The following is a description of a gene set: Any process that modulates the rate, frequency, or extent of the series of molecular signals generated as a consequence of a transmembrane receptor serine/threonine kinase binding to its physiological ligand. Mouse Gene Set: GOBP_REGULATION_OF_TRANSMEMBRANE_RECEPTOR_PROTEIN_SERINE_THREONINE_KINASE_SIGNALING_PATHWAY studied in species Mus musculus, and this is the list of marker genes: Fkbp1a, Fzd1, Lrrc32, Fstl1, Kdr, Spart, Nrep, Amh, Lrg1, Ogt, Crb2, Ark2c, Fkbp8, Dnm2, Pin1, Tbx20, Smurf2, Dlx1, Cidea, Fstl3, Tnfaip6, Ing1, Fbn1, Nepn, Onecut2, Eng, Gata4, Ints9, Acvr2a, Gdf6, Nbl1, Sap30, Usp15, Sin3a, Men1, Rnf111, Ube2o, Ccn1, Tcf7l2, Fbn2, Sfrp1, Sfrp2, Trp53, Sfrp4 (secreted frizzled-related protein 4), Ovol2, Tgfb1i1, Adissp, Snx1, Zbtb7a, Spred2, Tmem53, Thbs1, Pals1, Pin1rt1, Spred3, Snx25, Chrdl1, Itga8, Gata6 (NCBI Gene Id 14465), Sostdc1, Dkk1, Snx6, Nanog, Zc3h3, Rgma, Myocd, Gdf15, Rbbp4, Ngly1, Dand5, Hdac2, Fst, Igsf1, Tgfb2, Cdkn1c, Chrdl2, Sulf1, Spred1, Hes1, Flcn, Emilin1, Nog, Adamtsl2, Slc2a10, Smad7, Numa1, Rbbp7, Sost, Brms1, Ski, Itga3 (integrin alpha 3), Lrp1, Hfe, Parp1, Suds3, Wnt5a, Neo1, Ppara, Arid4b, Vwc2l, Rasl11b, Cdh5, Aspn, Tgfbr2, Fstl4, Atoh8, Trim33, Brms1l, Zfp423, Gdf7, Sirt1, Cited2, Rbpj, Ccn3, Gpc3, Rbpms2, Bmper, Fbxl15, Nrros, Il17rd, Mir210, Ing2, Hdac1, Cav2, Gpr155, Zfp451, Lats2, Hes5, Veph1, Lefty1, Skil, Zfp703, Vwc2, Hoxa13 (NCBI Gene Id 15398), Lrp2, Vsir, Npnt, Twsg1, Gdf3, Xbp1, Tmprss6, Prmt1, Tet1, Bcl9l, Pbld1, Gdf5, Chst11, Zfyve9, Wnt1, Bmp2, Ppm1a, Bmpr2, Crebbp, Dmrt1, Dact2, Sox11, Gdf2, Lemd2, Csnk2b, Axin1, Ucma, Hjv, Pelo, Bmp7, Magi2, Ltbp1, Kcp, Il17f (NCBI Gene Id 96930), Snw1, Bmpr1a, Erfe, Cdh3, Pdpk1, Ldlrad4, Acvrl1, Zeb1, Got1, Inhba, Onecut1, Hsp90ab1, Sh2b1, Gdf11, Cdkn2b (cyclin dependent kinase inhibitor 2B), Foxd1, Furin, Glg1, Mtmr4, Acvr2b, Prdm16, Bmp6, Tgfb3, Tfap2b, Dab2, Synj2bp, Lats1, Ep300, Wfikkn2, Smad2 (NCBI Gene Id 319898), Tgfbr3, Crim1, Spry2, Smad4, Grem2, Ctdspl2, Stk11, Lox, Msx1, Smurf1, Chrd, Notch1, Eid2, Tsc22d1, Ilk, Cer1, Ryr1, Dact1, Skor2 (NCBI Gene Id 664805), Cav1, Fstl5, Htra3, Nodal, Mir675, Htra1, Grem1, Nkx2-1, Gipc1, Bmp5, Sap30l, Lemd3, Skor1, Lgals9, D130043K22Rik, Cripto, Cav3, Cilp, Sap130, Bmp10, Notch2, Spry1, Fgf10, Folr1, Fgf9, Sdcbp, Scube3, Nup93, Bambi (BMP and activin membrane-bound inhibitor), Pparg, Smad6, Jak2, Bmp4, Wfikkn1, Fam89b, Glce, Pbld2, Tgfb1, Acvr1, Pmepa1, Vasn, Abl1 (c-abl oncogene 1, non-receptor tyrosine kinase), Fermt1, Hipk2, Stub1, Zeb2, Adam17, Strap, Smad3, Tob1, Arid4a, Acvr1b, Cd109, Tgfbr1, Sorl1 (NCBI Gene Id 72910), Hspa5, Tgfbr3l, Peg10, Msx2, Sinhcaf, Elapor2